The following is a description of a gene set: part of: Cellular responses to stress Reactome Pathway: HSP90 chaperone cycle for steroid hormone receptors (SHR) in the presence of ligand species: Homo sapiens Steroid hormone receptors (SHR) are transcription factors that become activated upon sensing steroid hormones such as glucocorticoids, mineralocorticoids, progesterone, androgens, or estrogen. Depending on SHR type and the presence of ligand, they show different subcellular localizations. Whereas both unliganded and liganded estrogen receptors (ERalpha and ERbeta) are predominantly nuclear, unliganded glucocorticoid (GR) and androgen receptors (AR) are mostly located in the cytoplasm and completely translocate to the nucleus only after binding hormone (Htun H et al. 1999; Stenoien D et al. 2000; Tyagi RK et al. 2000; Cadepond F et al. 1992; Jewell CM et al. 1995; Kumar S et al. 2006). The unliganded mineralocorticoid receptor (MR) is partially cytoplasmic but can be found in nucleus in the ligand-bound or ligand-free form (Nishi M & Kawata M 2007). The progesterone receptor (PR) exists in two forms (PRA and PRB) with different ratios of nuclear versus cytoplasmic localization of the unliganded receptor. In most cell contexts, the PRA isoform is a repressor of the shorter PRB isoform, and without hormone induction it is mostly located in the nucleus, whereas PRB distributes both in the nucleus and in the cytoplasm (Lim CS et al. 1999; Griekspoor A et al. 2007). In the absence of ligand, members of the steroid receptor family remain sequestered in the cytoplasm and/or nucleus in the complex with proteins of HSP70/HSP90 chaperone machinery (Pratt WB & Dittmar KD1998). The highly dynamic ATP-dependent interactions of SHRs with HSP90 complexes regulate SHR cellular location, protein stability, competency to bind steroid hormones and transcriptional activity (Echeverria PC & Picard D 2010). Understanding the mechanism of ATPase activity of HSP90 is mostly based on structural and functional studies of the Saccharomyces cerevisiae Hsp90 complexes (Meyer P et al. 2003, 2004; Ali MM et al. 2006; Prodromou C et al. 2000; Prodromou C 2012). The ATPase cycle of human HSP90 is less well understood, however several studies suggest that the underlying enzymatic mechanisms and a set of conformational changes that accompany the ATPase cycle are highly similar in both species (Richter K et al. 2008; Vaughan CK et al. 2009). Nascent SHR proteins are chaperoned by HSP70 and HSP40 to HSP90 cycle via STIP1 (HOP) (and its TPR domains) (Hernández MP et al. 2002a,b; EcheverriaPC & Picard D 2010; Li J et al. 2011). The ATP-bound form of HSP90 leads to the displacement of STIP1 by immunophilins FKBP5 or FKBP4 resulting in conformational changes that allow efficient hormone binding (Li J et al. 2011). PTGES3 (p23) binds to HSP90 complex finally stabilizing it in the conformation with a high hormone binding affinity. After hydrolysis of ATP the hormone bound SHR is released from HSP90 complex. The cytosolic hormone-bound SHR can be transported to the nucleus by several import pathways such as the dynein-based nuclear transport along microtubules involving the transport of the entire HSP90 complex or nuclear localization signals (NLS)-mediated nuclear targeting by importins (Tyagi RK et al. 2000; Cadepond F et al. 1992; Jewell CM et al. 1995; Kumar S et al. 2006). It is worth noting that GR-importin interactions can be ligand-dependent or independent (Freedman & Yamamoto 2004; Picard & Yamamoto 1987). In the nucleus ligand-activated SHR dimerizes, binds specific sequences in the DNA, called Hormone Responsive Elements (HRE), and recruits a number of coregulators that facilitate gene transcription., and this is the list of marker genes: TUBA1A, FKBP5, TUBB1, NR3C2, TUBB2A, HSP90AB1, TUBB4B, HSPA2, DYNC1LI2, HSPA1A (NCBI Gene Id 3303), TUBAL3, HSPA8, TUBB8B, HSPA1B, TUBB6, TUBB8, TUBA4B, DYNC1I2, DCTN2, ACTR1A, DCTN3, DNAJA2, CAPZA1, DNAJA1, HSP90AA1, TUBA3E (NCBI Gene Id 150521), NR3C1, DYNLL2, TUBB3, HSPA1L, PGR, DYNLL1, DNAJB1, FKBP4, TUBA1B, TUBA3C, PTGES3, STIP1, CAPZA3, DYNC1I1, TUBA4A, TUBB2B, ACTR10, CAPZA2, CAPZB, DCTN6, DNAJA4, DCTN1, TUBA1C, TUBA8, AR, TUBB4A, TUBA3D, DYNC1H1, DCTN5, DCTN4, DYNC1LI1